The following is a description of a gene set: Mouse Gene Set: MIR_3095_5P from publication Chen Y, Wang X (PMID 31504780) species: Mus musculus Genes predicted to be targets of miRBase v22 microRNA mmu_miR_3095_5p in miRDB v6.0 with MirTarget v4 prediction scores > 80 (high confidence targets)., and this is the list of marker genes: Msi2, Rimkla, Ndst1, Mdn1, Mthfd2, Bcap29, Slc8a1, Ier5, Tfcp2l1, Cdh19, Kbtbd8, Proz, Ucp1 (NCBI Gene Id 22227), Kcns2, Gabrg2, Stag2, Pgr15l, Dr1 (NCBI Gene Id 67362), Dzip3, Znrf3, Serpine1, Slk, Morc4, Mtdh, Fibin (NCBI Gene Id 67606), Peak1, Snap25, Nefm, Cdr2, Map4k5, Sap18, Lats2, Slc35d2 (solute carrier family 35, member D2), Dynll1, Ppp4r3b, Trpc5, Plppr4, Plscr2, Ube2k, Ubxn7, Afdn, Cdkl4, Cep170, Pds5b, Zbtb8b, Patz1, Edem3, Gbp8, Sptssa, Limk2, Lipo1, Nr4a3, Vps26c, Nfat5, Saxo2, Aqp4, Sfpq, Pon2, Rexo2, Sar1a, Fbxl7, Mcl1, Lgr4, Ppp3ca, Arrdc3, Tafa5, Spin1, Ube2b (ubiquitin-conjugating enzyme E2B), Gdf10, Gnal, Sgpp1, Slc25a17, Rbm15, Meioc, Tmf1, Zfhx4, Exo1, Unc80, Dcdc2a, Entrep2, Naa30, D030056L22Rik, Elmod2 (NCBI Gene Id 244548), Fam171a1, Heatr5a, Gfra1, Clasp2, Il6st, Setd1b, Lpp, Gsta3, Dab2, Ctnnd2, Zfp704, Egln1, Sntb2, Mbd1, Dhx15, Dpp8, Gm8978, Tfap2b